Given this list of marker genes WNT11 (NCBI Gene Id 7481), ADAMTS9, JAG1, COMP, PDGFRB, SRF, MYOCD (NCBI Gene Id 93649), MIR495, FGF8, HEY2, BMPR1A, MIR205, ZMIZ1, COL3A1, LRP1, RTN4, NOTCH1, APOE, ADGRF5, PRDM1, MEGF8, APOB, NAGLU, ANGPTL3, TBX2, STRA6, NOTCH3, VEGFA, FOXC2, NOG, HES1, EFEMP2, EYA1, DLL4, BMP4 (NCBI Gene Id 652), FOXF1, HOXA1, MIR145, EDNRA, PROX1, SMAD7, EFNB2, TGFBR1, LDLR, HOXA13, NF1, PKD2, AKT3, MIR143, TBX1, HEY1, NRP1, GJA5, SEC24B, SIX1, CHD7, MDK, HAND2, BMPR2, TGFBR2, MIR329-1 (NCBI Gene Id 574408), SOX4, ENG, MIR494, CITED2 (Cbp/p300 interacting transactivator with Glu/Asp rich carboxy-terminal domain 2), FOXC1, FKBP10, MIR29B1, MIR487B, ACVRL1, TGFB2, LRP2, MIR153-1, NPRL3, TFAP2B, FOLR1, ARID2 (NCBI Gene Id 57676), FOXH1, HPGD, EDN1, PRRX1, MYLK (myosin light chain kinase), RBPJ, NFATC3, here is a description of the gene set: Human Gene Set: GOBP_ARTERY_MORPHOGENESIS studied in species Homo sapiens The process in which the anatomical structures of arterial blood vessels are generated and organized. Arteries are blood vessels that transport blood from the heart to the body and its organs.